Given this list of marker genes MAPK8, MAFG, MAFK, CYP2E1, MAFF, MAP2K1, SP1, NFE2L2, MAP2K2, here is a description of the gene set: species: Homo sapiens Ethanol metabolism production of ROS by CYP2E1 Human Gene Set: WP_ETHANOL_METABOLISM_PRODUCTION_OF_ROS_BY_CYP2E1